Given this list of marker genes Gck, Camk2n1, Ghrl, Gpr68, Sox4, Edn3, Inhbb, Clcf1, Crhr2, Ecrg4, Cartpt, Eipr1, Rab11fip1, Nell2 (NEL-like 2), Uts2, Hfe, Tardbp, Nadk, Vsnl1, Rest, Hmgcr, Sct, Rptor, Foxa2, Scg5, Fam3d, Ghsr, Hcfc1, Pde8b, Nos1 (nitric oxide synthase 1, neuronal), Capn10, Smad4, Il11, C1qtnf12, Myh9, Crh, Abca12, Epha5, Gper1, Stxbp4, Foxo1, Syt7, Mir200a, Htr2c, Sirt4, Adra2a, Jagn1, Trpm2, Pde3b, Rasl10b, Kcnj6 (potassium inwardly-rectifying channel, subfamily J, member 6), Nr1d1, Apln, Adcy5 (NCBI Gene Id 224129), Slc30a8, Map4k4, Trpm4, Cd38, Arrb1, Trh, Fgb, Irs1, Nos2, Arhgef7, Ndufaf2, Ensa, Pla2g3, Rac1, Glp1r, Foxl2 (NCBI Gene Id 26927), Mir130a, P2ry1, Mup2, Kif5b, Cdk16, Ppp3cb, Vdr, Aacs, Nlgn2, Trpc1, Syt9, Slc2a2, Sri (sorcin), Acsl4, Adora1, Tcirg1, Myt1, Npff, Myb, Tfap2b, Prkaca, Inha, Crhr1, Irs2, Mfn2, Gpr39, Cacna1d (NCBI Gene Id 97919), C1qtnf3, Chrm3, Bmal1, Hmgn3, Cacna1e, Mtnr1b, Uqcc2, Hcar2, Rfx3, Cckar, Acvr1c, Adipoq, Grp, Cpt1a, Nmu, Tcf7l2, Ffar2, Mup3, Prkar1a, Nkx3-1, Sidt2, Trpm5, Nmb, Runx1, Cyp19a1, Gprc6a, Pax8, Rab8b, Eny2, Serp1, Sfrp1, Lep, Bmp6, Klf7, Nrg1, Ppard, Prkce, Sstr5, Ptprv, Gdf9, Ren1, Gpr27 (NCBI Gene Id 14761), Gja1, Mlxipl, Mup11, Ucn, Hnf1a, Ucn3, Fgfr4, Acvr2a, Gip, Fgg, Pfkl, Lif, Tspo, Pfkfb2, Htr1a, Ghrh, Ucn2, Osbp, Mup1, Nr1h4, Pde4c, Rfx6, Gcg, Tiam1, Gna11, Abat, Npvf, C2cd2l (NCBI Gene Id 71764), Il1b, Myrip, Pask, Ccl5, Pomc, Kalrn, Rph3al, Hadh, Fbn1, Cftr, Isl1, Fkbp1b, Mpc2, Kcnq1 (potassium voltage-gated channel, subfamily Q, member 1), Cnr1, Tmf1, Inhba, Slc25a22, F2, Pick1, Ptger4, Stx4a, Pla2g6, Ptger3, Kdm5b, Chd7, Sirt6, Mup4, Doc2b, Cela2a, Ccn3 (NCBI Gene Id 18133), Anxa7, Slc8b1, Chga, Ffar4, Midn, Ffar3, Anxa5, Edn2, Birc5, Ucp2, Creb1, Tacr1, Lepr, Il6, Tnfsf11, Ghrhr, Pex5l, Ptbp1, Sybu, Rbp4, Ppp3ca, Retn, Spp1, Prkn, Glud1, Hif1a, Nnat, Nr0b2, Oprk1, Madd, Slc9b2, Itsn1, Efna5, Sirt1, Clock, Zbed6, Sox11, Prkd1, Galr1, Abcg1, Tacr2, Mup5, Osm (NCBI Gene Id 18413), Gnaz, G6pc2, Ano1, Abcc8, Anxa1, Ptpmt1, Brsk2, F2rl2, Per2, Rab11fip5, Plcb1, Pck2, Igfbp3, Gnai1, Edn1, Fgf23, Nkx6-1, Kiss1r, Agt, Prkcb, Pfkm, Cyp2j5, Kcnj11, Gnaq, Snx4, Vamp8, Bglap2, C1qtnf1, Hmga2, Sirt3, Dab2, Aimp1, Glul, Dynll1, Agtr2 (angiotensin II receptor, type 2), Pparg, Gnao1, Nucb2, Adcyap1, Casr, Pim3, Stxbp5l, Stim1, Rapgef4, Oprm1, Cacna1c, Fgfr1 (NCBI Gene Id 14182), Drd2, Tac1, Crhbp, Blk, Pdx1, Kiss1, Gnas, Ildr1, Selenot, Atg7, Cckbr, Cntf (ciliary neurotrophic factor), Oga, Ffar1, Alox5, Ncoa6, Tunar, Agtr1a, Kcnk9, Lrrc8a, Cry1, Mcu, Bad, Egfr, Jak2, Sytl4, Adcy8, Lrp5, Cask, Mtnr1a, Npy1r, Slc16a1, Itpr1, Ifng, Kcnb1, Trpa1, Fga, Tbc1d1, Gabbr1, Cry2, Nppa, Rab11fip3, Gpld1, Piwil4, Gal, Ptpn11, F2rl1, Gipr, Tm7sf3, Snap25, Baiap3, Oxct1, Hnf4a, Orai1, Tnf, Lrp1, Tfr2, Mir410, Srebf1, Psmd9, Cyp27b1, Fto, Pde1c, here is a description of the gene set: Any process that modulates the frequency, rate or extent of the regulated release of a hormone from a cell. species: Mus musculus Mouse Gene Set: GOBP_REGULATION_OF_HORMONE_SECRETION